The following is a description of a gene set: Human Gene Set: GOMF_PHOSPHATIDYLINOSITOL_3_KINASE_INHIBITOR_ACTIVITY Binds to and decreases the activity of a phosphatidylinositol 3-kinase (PI3K). species: Homo sapiens, and this is the list of marker genes: WASHC1 (WASH complex subunit 1), WDR81, WDR91, RUBCN, ATG14, PIK3IP1